Given this list of marker genes MGAT2, AHCYL1, SLC35F2, PARK7, PPM1D, ZNF267, SRSF9, MTMR4, TRAF1, AHSA1, ALDOA, FDPS, TANK, ITPA, RRM1, MYL6B, NDUFB3, PPP1R10, HBS1L, SEC61B, PPP2R1B, MRPL18, HSD17B12, NPEPPS, DARS1, KIFBP, ZBTB6, TRNAU1AP, ARCN1, CDT1, BET1, SACM1L, ATP5PB, DDB2, YIF1A, CISH, DIABLO, LARP4B, SF3B4, CSNK2A1, CYFIP1, COX8A, MRPS16, PAAF1, CANT1, CRTAM, GCLM, RNF34, SLC1A5 (NCBI Gene Id 6510), HPRT1, NUP93, SDC4, SLC16A1 (solute carrier family 16 member 1), SCAMP3, LBHD1, GTF2E1, GNG10, ARID5A, ERCC1, OXSM, NDUFAF3, IMMT, FAH, HIGD1A, NSMAF, GPR171, REEP5, POP4, YWHAE, COX17, APBA3 (NCBI Gene Id 9546), ELAVL1, ATOX1, HINT1, PSMC2 (proteasome 26S subunit, ATPase 2), TARS1, CD2BP2, GRK3, MRPL42, CCR1, BAX, TYMS, TSG101, MED8, ZNF207, MLH1, LIF, CCND2, MICAL2, TP53BP1, CDK2, ETFA, MAMLD1, GALNT3, PNP, NCBP1, MIF (NCBI Gene Id 4282), ACSL3, KPNA3, MPDU1, TGDS, PTPRK, SEPTIN8, ZBTB24, TAP1, GLRX2, ZWINT, DGUOK, MTHFD1, UBFD1, SRP19, PRDX3, STARD7, AIFM1, PDCD6 (programmed cell death 6), RACGAP1, PCNA, NFKBIB, MMUT, MRPL17, KCTD5, PPCDC, TMED2, NAPG, PFKP, PSMB1, FKBPL, CLDND1, FANCI, TARDBP, POMP, TRIP12, COPB2, WDR5B, TFG, SMCO4, MANF, TMEM258, UQCC1, STX6 (NCBI Gene Id 102724791), EIF4G1, FAF2, RAB23, NME7 (NCBI Gene Id 29922), RBM23, FAR2, KLHL23, NDUFAF1, PRDX4, VDAC3, AASDHPPT, PSMD5, JTB, TRIM32, AQR, TFRC, NCOA3, SLC25A44, GALK1, GFPT1, TIMM8B, ETNK1 (ethanolamine kinase 1), GOLT1B, FAM3C, TBC1D10B, SEC24D, PSMA1, BCOR, ENOPH1, CCRL2, GET1, OSBPL3, JAK2, CLTC, SNRNP40, ZNF175 (zinc finger protein 175), DNPH1, PSME2, IFT25, MINPP1, TPI1, BAG2, SDF2, ARMT1, IGFLR1, CNIH4, SPATS2L, MRPL16, TMEM223, ITPR1, FURIN, NME6, MTCH2, NEK7, COPS4, ISOC1, CSTF2, WDR18, RAB21, CCDC47, here is a description of the gene set: Genes down-regulated in comparison of naive CD4 T cells versus stimulated CD4 Th2 cells at 12 h. Immune cell-specific expression is one indication of the importance of a gene's role in the immune response. In order to identify such patterns, we set out to broadly profile gene expression in a variety of immune cells. Human Gene Set: GSE22886_NAIVE_CD4_TCELL_VS_12H_ACT_TH2_DN species: Homo sapiens from publication Abbas AR, Baldwin D, Ma Y, Ouyang W, Gurney A, Martin F, Fong S, van Lookeren Campagne M, Godowski P, Williams PM, Chan AC, Clark HF (PMID 15789058)